Given this list of marker genes HOOK3, BCAT1, CEP68, TPM3, EDARADD (NCBI Gene Id 128178), ACY1, AMZ1, STXBP1, PACC1, SIVA1, UTP25, DDX19B, GID4, TRA2A, POLH, SNORD52, PRKACB, ITSN1, TMOD1, KIF7, SLC29A1, GCN1, DYRK2, KLF9, NOLC1, LINGO3, BMAL2 (NCBI Gene Id 56938), CCDC85C, SF3A3, MND1, AFF3, FAM43A, CFAP298, MTHFD1, SERF1A, NT5DC2 (NCBI Gene Id 64943), CTH, CPSF2, SLC16A1, SOD2, RBM38, RPL23, SRFBP1, ANKRD37, TFRC, CLASP2, IQGAP1, PABPC1, CNN3, EPRS1, SMPD4, SOX4, SGMS1, BCL7A, CROCC, TMEM143, EPS8, BACH2, TAF1D, PTK2, SCARB1, NIBAN3, SHMT1, ATAD1, SNORD12C, CDKN1A, TRIM2, RAD51B, ESCO2, IDI1, KLC1, IRAG2, NCL, INCENP, CHML, SART3, RCOR1, XYLB, MYL4, GABPB2, SBK1, BCL11A, FUS, BAG2, PKIG, FARSB, GDPD3 (glycerophosphodiester phosphodiesterase domain containing 3), DIRAS2, RAD54L, DIRAS1, SRGAP2, AP1S3, FANCA, AKAP12, PDLIM1, PTPRS, VPREB1, USP25, POT1, SUPT16H (SPT16 homolog, facilitates chromatin remodeling subunit), NUDT21, ESRRB, PPM1E, BPNT1, DNAJB4, SNRPF, GAR1, FUBP1, TARBP1, MARK3, ZNF593, ZEB2, ATP5PO, TIFA, CECR2, MRPS6, PINLYP, GCH1, RHOH, EGFL6, GSDME, BRD8, CHCHD6, BAMBI, YWHAG, SAPCD1, NORAD, NAT8L, AGPAT5, DYNLT2, ID3, GPAT3, POFUT1, BCL2L1, EBF1, SNHG8, NAP1L1, PAX5, LGR6, OTUB2 (NCBI Gene Id 78990), here is a description of the gene set: Human Gene Set: BOYLAN_MULTIPLE_MYELOMA_C_D_UP from publication Boylan KL, Gosse MA, Staggs SE, Janz S, Grindle S, Kansas GS, Van Ness BG (PMID 17483317) Multiple myeloma is an incurable plasma cell malignancy for which existing animal models are limited. We have previously shown that the targeted expression of the transgenes c-Myc and Bcl-X(L) in murine plasma cells produces malignancy that displays features of human myeloma, such as localization of tumor cells to the bone marrow and lytic bone lesions. We have isolated and characterized in vitro cultures and adoptive transfers of tumors from Bcl-xl/Myc transgenic mice. Tumors have a plasmablastic morphology and variable expression of CD138, CD45, CD38, and CD19. Spectral karyotyping analysis of metaphase chromosomes from primary tumor cell cultures shows that the Bcl-xl/Myc tumors contain a variety of chromosomal abnormalities, including trisomies, translocations, and deletions. The most frequently aberrant chromosomes are 12 and 16. Three sites for recurring translocations were also identified on chromosomes 4D, 12F, and 16C. Gene expression profiling was used to identify differences in gene expression between tumor cells and normal plasma cells (NPC) and to cluster the tumors into two groups (tumor groups C and D), with distinct gene expression profiles. Four hundred and ninety-five genes were significantly different between both tumor groups and NPCs, whereas genes were uniquely different from NPCs in tumor group C and genes were uniquely different from NPCs in tumor group D. Similar to human myeloma, the cyclin D genes are differentially dysregulated in the mouse tumor groups. These data suggest the Bcl-xl/Myc tumors are similar to a subset of plasmablastic human myelomas and provide insight into the specific genes and pathways underlying the human disease. Genes up-regulated both in group C and D of tumors arising from overexpression of BCL2L1 and MYC in plasma cells. studied in species Mus musculus